The following is a description of a gene set: Human Gene Set: GOCC_VCP_NPL4_UFD1_AAA_ATPASE_COMPLEX A multiprotein ATPase complex required for the efficient dislocation of ER-lumenal degradation substrates, and their subsequent proteolysis by the proteasome. In budding yeast, this complex includes Cdc48p, Npl4p and Ufd1p proteins. In mammals, this complex includes a hexamer of VCP/p97 (a cytosolic ATPase) and trimers of each of its cofactors UFD1L and NPL4 (NPLOC4) (e.g. a 6:3:3 stoichiometry). species: Homo sapiens, and this is the list of marker genes: RNF125, UBXN1 (UBX domain protein 1), FAF1, AFG2B, UBXN7, FAF2, VCP, UFD1, NPLOC4